Given this list of marker genes Rab38, Zeb2, Pmel, Tyrp1, Opn3, Gipc1, Atp7a, a, Appl1, Cdh3, here is a description of the gene set: Any process that activates or increases the frequency, rate or extent of secondary metabolite biosynthetic process. Mouse Gene Set: GOBP_POSITIVE_REGULATION_OF_SECONDARY_METABOLITE_BIOSYNTHETIC_PROCESS studied in species Mus musculus